Given this list of marker genes Traf6, Gm13880, Caprin1, Cd59a, Pin1rt1, Gm13921, Gm13877, Gm13884, 4931422A03Rik, Cd44, Gm13886, Gm13919, D430041D05Rik, Gm13882, Depdc7, Gm13879 (NCBI Gene Id 100042965), Fjx1 (four jointed box 1), Prr5l, Rag2, Gm13869, Elf5, Pamr1, Wt1os, Platr14, Eif3m, Ldlrad3, Commd9, Cstf3, Nat10, Abtb2, A930018P22Rik, BC016548, Fbxo3, Gm22501, Rag1, Gm13883, Hipk3, Iftap, Gm13875, Cd59b, Cat (catalase, NCBI Gene Id 269322), Pdhx, Lmo2, Prrg4, Qser1, Gm13888, Slc1a2, Ccdc73, Mir1902, Wt1, 4930547E08Rik, Gm13866, Ehf (NCBI Gene Id 99194), A930006I01Rik, Gm13870, Trim44, Tcp11l1, Apip, Gm23439, Gm13920 (NCBI Gene Id 100642184), Gm13868, Gm24644, Gm13872, here is a description of the gene set: studied in species Mus musculus Mouse Gene Set: chr2E2